The following is a description of a gene set: Any response to laminar fluid shear stress in a vascular endothelial cell. Human Gene Set: GOBP_VASCULAR_ENDOTHELIAL_CELL_RESPONSE_TO_LAMINAR_FLUID_SHEAR_STRESS studied in species Homo sapiens, and this is the list of marker genes: PDPK1, PRKACB, AKT1, PKN2, PRKACG, PRKACA, MTOR, CAPN2, GNAS